Given this list of marker genes IQGAP3, SMO, MSX1, WNT2, CCL11, CEBPB, FOXF1, WNT5A, DDR1, CDKN2A, ROBO1, FOXB1, MED1, SRC, BRCA2, RREB1, GPX1, PML, MSX2, STAT5A, CSF1, ELF5, JAK2, DEAF1, TFAP2C, NR3C1, LBH, ID2, BAX, AKT2 (NCBI Gene Id 208), BTRC, ZNF703, ORAI1 (ORAI calcium release-activated calcium modulator 1), WNT3, PGR, PTCH1, NTN1, ETV5, STAT6, IRF6, FGF10, PRLR, PERP, CSMD1, SCRIB, LRP5, FGFR2, GATA3, CCND1 (cyclin D1), ESR1, CAV3, CSF1R, AREG, EPHA2, PHB2, FGF2, HOXA5 (NCBI Gene Id 55953), HIF1A, VDR, AKT1, PYGO2, KDM5B, LATS1, AR, TBX3, TGFB1, RTN4, WNT7B, TNFSF11, WNT4, ATP2C2, MAPK1 (NCBI Gene Id 5594), SOSTDC1, ERBB4, here is a description of the gene set: The process whose specific outcome is the progression of the mammary gland epithelium over time, from its formation to the mature structure. The mammary gland is a large compound sebaceous gland that in female mammals is modified to secrete milk. Human Gene Set: GOBP_MAMMARY_GLAND_EPITHELIUM_DEVELOPMENT species: Homo sapiens